Given this list of marker genes CYBA, TGFB1, AGT, RAC1, TAFA4, PRG3, ITGAM, CRP, NOX1, SH3PXD2A, ELAVL1, NOX5, SYK, SH3PXD2B, TYROBP, ITGB2, GSTP1, NOX4, FPR2, RAC2, NCF1C, NCF1, PRKCE, ALOX12, NCF4, ACP5, DUOX1, GNAI2, CLEC7A, SOD1, PON3, NCF1B, PRKCD, NOXA1, NOXO1, CYBB, F2RL1, APP, CD177, SOD2, NOX3, EDN1 (NCBI Gene Id 1906), NCF2, DUOX2, MAPT, here is a description of the gene set: species: Homo sapiens The enzymatic generation of superoxide, the superoxide anion O2- (superoxide free radical), or any compound containing this species, by a cell in response to environmental stress, thereby mediating the activation of various stress-inducible signaling pathways. Human Gene Set: GOBP_SUPEROXIDE_ANION_GENERATION